The following is a description of a gene set: Reactome Pathway: Defective MAT1A causes MATD part of: Metabolic disorders of biological oxidation enzymes studied in species Homo sapiens S-adenosylmethionine (AdoMet, SAM) is an important methyl donor in most transmethylation reactions. S-adenosylmethionine synthase isoform type-1 (MAT1A) catalyses the formation of AdoMet from methionine and ATP. Defects in MAT1A can cause methionine adenosyltransferase deficiency (MATD; MIM:250850), an inborn error of metabolism resulting in hypermethioninemia. In this condition, methionine accumulates because its conversion to AdoMet is impaired., and this is the list of marker genes: MAT1A